The following is a description of a gene set: Genes predicted to be targets of miRBase v22 microRNA mmu_miR_344_5p, mmu_miR_344b_5p, mmu_miR_344c_5p, mmu_miR_344d_1_5p, mmu_miR_344d_3_5p in miRDB v6.0 with MirTarget v4 prediction scores > 80 (high confidence targets). species: Mus musculus Mouse Gene Set: MIR_344_5P_MIR_344B_5P_MIR_344C_5P_MIR_344D_1_5P_MIR_344D_3_5P from publication Chen Y, Wang X (PMID 31504780), and this is the list of marker genes: Rad21, Zscan22, Cd59b, Catsperg2, Blzf1, Tcte1, Bmp2, Pttg1ip, Azgp1, Wdr33 (WD repeat domain 33), Cd59a, Sbf2, Gch1, Has2, Nfix, Ppargc1a, Rtcb, Srsf2, Adgrl2, Hivep2, Tmsb15b1, Ccl6, Gpm6a, Capn6, Ubqln3, Kcnma1, Ola1, Lancl2 (LanC (bacterial lantibiotic synthetase component C)-like 2), Cd209e, Gata1, Sln, Adgrb3, Dennd1b, Fam120c (family with sequence similarity 120, member C), Mrpl21, Rreb1, Igf1r, Acsl3